Given this list of marker genes Nsun2, Xpnpep1, Ehbp1l1, Actn4, Atp11a, Morc2a, Polb (NCBI Gene Id 320892), Col4a2, Adamts3, Psph, Kifbp, Capza2, Prmt7 (protein arginine N-methyltransferase 7), Ssr2, Gas2l2, here is a description of the gene set: Mouse genes annotated to increased trigeminal neuroma incidence (MP:0013875) retrieved from the Mouse Genome Informatics database via MouseMine from publication Motenko H, Neuhauser SB, O'Keefe M, Richardson JE (PMID 26092688) Mouse Gene Set: MP_INCREASED_TRIGEMINAL_NEUROMA_INCIDENCE species: Mus musculus